Given this list of marker genes Abcb9, Usp24, Peg10, Usp38, Cep135, Adamts12, Prtg, Syt11, Prpf38b, Col4a2, Brwd1, Pcgf3, Mapk8, Klf8, Stxbp5, Trhde, Thoc1, Fgd6, Atp2a2, Fras1 (Fraser extracellular matrix complex subunit 1), Ltn1, Tmprss2, Hif1an, Sigmar1, Map4k3, Col1a2 (collagen, type I, alpha 2), Ddx19b, Gpcpd1, Col3a1, Adrb2, Asap1, Hmga2, Slc2a12, Utrn (NCBI Gene Id 22288), 2310022A10Rik, Arhgap28, Dtx2, Clasp2, Mfsd4a, Cd200r1, Macf1, Tyk2, Plpp5, Cnot6l, Brd3, Yod1, Ints6l, Wnt9a, Rab8b, Dpp3, Ttll4, Cflar, Dmd, Lipt2, Nek3, Dlc1, Klhl6, Slc66a1, Rbms2, Plpp6, Slc10a7, P4ha2 (procollagen-proline, 2-oxoglutarate 4-dioxygenase (proline 4-hydroxylase), alpha II polypeptide), Pitpnm3, Rictor, Igf2bp3, Dnaja2, Arhgef15, Homer2, Stk40, Fndc3a, Tbkbp1, Plekha8, Wasl, Tmem65, Dusp1, 1700017B05Rik, Il6, Dusp22, Gpr156, Zmat4, Nipal4, Mycn, Fgf11, Igdcc3, Klk10, Atl2, Nemp1, Intu, Xkr8, Cep120, Nol4l, Wdfy3, Adamts15, Scyl3, Gcat, Ndst2, Sall4, Ercc6, Acvr1c, Snx30, Gas7, Adrb3, Nme6, Masp1, Rab11fip4, Limk2, Zfyve26, Zfp975, Ap1s1, Smarcad1, Frmd4b, Thoc2, Gxylt1 (glucoside xylosyltransferase 1), Ddi2, Pbx1, Stard13, Skil, Kctd17, Casp3, Rgs6, Cpa4 (NCBI Gene Id 71791), Taf9b, E2f6, G6pc2, Cbx2, Rdx, Cpeb2, Ccnd2, Pappa, Sowaha, Zbtb5, Ptafr, Faxc, Rbfox2, Gga3, Plxnc1, Senp2, Fndc3b, Usp47, 9930012K11Rik, Fam135a, Adamts8, Hectd2, Kctd21, Dna2, Bcat1, Greb1l, Slc25a24, Gramd2b, Pde12, Rspo2 (R-spondin 2), Zc3hav1l, Col4a1, Hdlbp, Col5a2, Slc35d2, Nynrin, E2f5, Arid3b, P2rx1, Map3k2, Liph, Zfp583, Begain, Coil, Crb2, Pard6b, Apbb3, Rasgrp1, Stx17, Plekhg6, Cpeb1, Ccnj, Onecut3, Mdm4, Igf2bp2, Gng5, Slc6a1, Tmod2, Slc20a1, Lbr, Ppargc1b, Dnase1l2, Kif2b, Ppp1r16b, Lin28b, Fnip1, Gpatch2 (NCBI Gene Id 98696), Slc25a27, Plekho1, Igdcc4, Dnajc1 (DnaJ heat shock protein family (Hsp40) member C1), Ybey, Stimate, Trim71, Gabra6, Pxdn, Etnk2, Ddx19a, Efhd2, Pla2g3 (NCBI Gene Id 237625), Ehhadh, Acat1, Zswim5, Has2, Pogz, Map3k1, Fnip2, Lrig2, Grid2ip, Tspan5, Fam174a, Entrep2, Pik3ip1, Rgs16, Hip1, Ccr7, Zfp275, Mycbp, Cemip2, Vstm5, Slc22a23, Soat2, Alox8, Arl5a, Trabd, Katnbl1, Myorg, Osmr, Elp1, Pbx3, Nap1l1, Stx3, Lgr4, Eea1, Rbpj, Hook1, Pald1, Rufy3, Limd2, Psd3, Slc7a14, Onecut2, Hand1, Tgds, Bsn, Arid3c, Fbxl12, Il13, E2f2 (NCBI Gene Id 329958), Smim3, Slc16a14, Trim6, Zfp282, Ints2, Tgfbr1, Dcaf15, Arid3a, Lpgat1, Ccdc71l, Cgnl1 (cingulin-like 1), Tmem198b, Edn1, Diaph2, Zbtb39, Kif21b, Mapk6, Leprotl1, Alg11, Slc38a9, Gdf6, Bach1, Cldn12, Nphp3, Cercam, Nr6a1, Scn11a, Sft2d3, Prrx1, Thrsp, Tgfbr3, Fignl2, Cdc34, Pcdh19, Tmprss11f, Sestd1, Ahctf1 (AT hook containing transcription factor 1), Sall3, Mdfi, Gpatch3, Ppp2r2a, Snn, B3gnt7, Hoxa1, Hic2, D630045J12Rik, Pbx2, Arpp19, Egln2, Tmc7, Igf2bp1, Prkaa2, Cbx5, Pacs2, Cry2, Plxnd1, Col27a1, Trim67, Gnptab, Map4k4, Fign, Galnt2, Txlng, Bzw1, Styk1, Tnfaip8l3, Zfp512b, Ngf, Kdm3a, Galnt1, 5031439G07Rik, Lrig3, Fasl, Tmco1, Lin28a, Nras, Sec16b, Mxd1, Slf2, Tet3, Trim41, Cntrl, Rfx6, Wnt9b (wingless-type MMTV integration site family, member 9B), Pcdh20, Igf1r, Smug1, Agap1, Arhgap12, Dtx4, Gatm, Eef2k, here is a description of the gene set: studied in species Mus musculus Genes predicted to be targets of miRBase v22 microRNA mmu_let_7a_5p, mmu_let_7c_5p, mmu_let_7e_5p, mmu_miR_98_5p in miRDB v6.0 with MirTarget v4 prediction scores > 80 (high confidence targets). from publication Chen Y, Wang X (PMID 31504780) Mouse Gene Set: LET_7A_5P_LET_7C_5P_LET_7E_5P_MIR_98_5P